The following is a description of a gene set: Catalysis of the transfer of an acyl group to an oxygen atom on the acceptor molecule. Human Gene Set: GOMF_O_ACYLTRANSFERASE_ACTIVITY studied in species Homo sapiens, and this is the list of marker genes: CPT1C, CASD1, CPT1A (NCBI Gene Id 1374), APOA4 (NCBI Gene Id 337), APOA5, MBOAT2, LCLAT1, APOC1, HHAT, AGPAT5, APOE, LPCAT2, MOGAT1, AGPAT4, PLA2G4A, GPAT2, GPAT4, AGPAT1, LPCAT1, AGPAT2, PRDX6, LRAT, PNPLA3, PLAAT1, AWAT2, LPGAT1, GPAT3, PNPLA4 (NCBI Gene Id 8228), MOGAT3, AWAT1, SOAT1, CRLS1, ABHD5, CPT1B, CRAT, DGAT2L6, GNPAT, DGAT2, DGAT1 (diacylglycerol O-acyltransferase 1), GPAM, TAFAZZIN, LPCAT3, CHAT, MBOAT7, MOGAT2, CROT, SOAT2, LPCAT4, LCAT, NAT2, PNPLA2, APOA2, APOA1, ACAT1, IFNB1, AGPAT3, MBOAT4, PIGW, PLA2G15 (phospholipase A2 group XV), PLA2G4C, MBOAT1, CPT2